Given this list of marker genes ACSBG1, CD24, CES2, STEAP3, DNAJB5, CYP27A1, FOXA2, NAP1L1, NRG1, PHYHIP, ACHE, DUS2, GPR3, CD44 (NCBI Gene Id 960), PCOLCE2, FXR1, SLC52A1, IL13RA1, MLN, ALPG, PRAME, MAP2K5, TWIST1, HAGH, WDTC1, FERMT2, BCAN, RPS14, KRT81, ASPHD1, KIF25, CRP (NCBI Gene Id 1401), TPT1, ACVRL1, ABCC6, LRRC41, NUDT3, CRYBB1, LZTS1, HEYL (NCBI Gene Id 92408), HROB, ICA1, AFDN, HGSNAT, CSF3, OMP, PRRG2, FOXC2, IGF2, CHRNA4, STEAP4, AMELY, KRT8, PROS1, MAPKAPK5-AS1, MYL11, AGPAT2, CHIT1, COL17A1, GPAA1, HADHA, TRIM15, HFE, OSBP2, ECI1, LPGAT1, SSR3, RTN3, SLC19A1, RBPMS, LTA4H, PINK1, EIF4B, BCAS3, ANGPTL3, CPNE6, NCOA4, P3H4 (NCBI Gene Id 10609), FOXL1, VIPR2, EIF3L (eukaryotic translation initiation factor 3 subunit L), CLDN3 (NCBI Gene Id 1365), LTF, SLC9A3, EIF3D, LRRC23, MFAP4, DAP3 (NCBI Gene Id 7818), MICAL2, RRAGD, KLK3, RAMP2, TACC2, MEG3, RPL4, IL17B, THBS4, CHMP3, PIERCE1, RAB13, CTNNBIP1, EIF2D, DUSP9, CRIP2, GRIN1, RPL17, ESR2, ELOB, FHL1, ENSG00000307536, SORL1, ETHE1, HSD17B11, PTPRS, PI3, PABPC4, RPL10L, CPNE3, TPM1, SLC14A1, ST8SIA3, NOL3, ATRN, CA1, YBX3, NR2F1, ADGRE3, BTF3, PRKAR2A, SH3PXD2A, BNIP3L, GSN, BRF1, TACSTD2, EPHB1, PCBP2, ORAI2, RAB31, CPD, HAUS4, PLEKHM1, TESC, SNCA, OTUD7B, RDH16, TRO, GAS7, EIF3F, SNORA70, RPL29P17, EVPL, PC (NCBI Gene Id 5091), RPS3A, SNX15, PPP2R5B, CYBRD1, KLKB1, RPL7P52, PLPPR3, REPS2, MS4A3, SERPINB10, SLC38A3, MAPT, SGCA, CRTAP, TNP1, KRT18P38, QARS1, ADI1, MECOM, KCNJ12, SSX5, ADIPOR1, here is a description of the gene set: Human Gene Set: GSE6269_FLU_VS_STREP_PNEUMO_INF_PBMC_DN Each infectious agent represents a unique combination of pathogen-associated molecular patterns that interact with specific pattern-recognition receptors expressed on immune cells. Therefore, we surmised that the blood immune cells of individuals with different infections might bear discriminative transcriptional signatures. Gene expression profiles were obtained for 131 peripheral blood samples from pediatric patients with acute infections caused by influenza A virus, Gram-negative (Escherichia coli) or Gram-positive (Staphylococcus aureus and Streptococcus pneumoniae) bacteria. Thirty-five genes were identified that best discriminate patients with influenza A virus infection from patients with either E coli or S pneumoniae infection. These genes classified with 95% accuracy (35 of 37 samples) an independent set of patients with either influenza A, E coli, or S pneumoniae infection. A different signature discriminated patients with E coli versus S aureus infections with 85% accuracy (34 of 40). Furthermore, distinctive gene expression patterns were observed in patients presenting with respiratory infections of different etiologies. Thus, microarray analyses of patient peripheral blood leukocytes might assist in the differential diagnosis of infectious diseases. studied in species Homo sapiens from publication Ramilo O, Allman W, Chung W, Mejias A, Ardura M, Glaser C, Wittkowski KM, Piqueras B, Banchereau J, Palucka AK, Chaussabel D (PMID 17105821) Genes down-regulated in comparison of peripheral blood mononuclear cells (PBMC) from patients with acute influenza infection versus PBMC from patients with acute S. pneumoniae infection.